The following is a description of a gene set: Mouse Gene Set: GOBP_DE_NOVO_PROTEIN_FOLDING species: Mus musculus The process of assisting in the folding of a nascent peptide chain into its correct tertiary structure., and this is the list of marker genes: Hspa5, Hspe1-rs1 (heat shock protein 1 (chaperonin 10), related sequence 1), Chchd4, Hspa1l, H2-DMb2, Hspa8, Hspe1, Hspa1a, St13, Tor1a, Entpd5, H2-DMb1, Cct3 (chaperonin containing TCP1 subunit 3), Hsph1, Hspa1b, Hspa2, Dnajb13, Hspa14, Ero1a, Cct7, Ptges3-ps, Cct4 (chaperonin containing TCP1 subunit 4), Cd74, Dnajc7, Dnajc2, Hspa13, Sh3glb1, Cct8, H2-DMa, Dnajb12, Dnajb5, Cct2, Dnajc18 (DnaJ heat shock protein family (Hsp40) member C18), Dnajb1, Dnajb14, Selenof, Bag1, Sdf2, Sdf2l1, Ptges3, Telo2, Tor2a, Hspa9, Tcp1, Dnajb4, Cct5, Tor1b